The following is a description of a gene set: Human Gene Set: HP_ABNORMAL_PERIPHERAL_MYELINATION Abnormal peripheral myelination An abnormality of the myelination of motor and sensory peripheral nerves. These are axons for motor nerves and dendrites for sensory nerves in the strict anatomic sense. species: Homo sapiens, and this is the list of marker genes: ARSA, RAI1, MOCS1, WNK1, VRK1, PNPT1, ERCC6, MT-ND6, SLC12A6, TDP1, KCNJ10, JPH1, TWNK, SBF1, YARS1, CTDP1, DCAF8, SPTLC1, NEFL, POLG, PRX, MT-TV, TYMP, GCDH, PEX16, MME, COX6A1, RAB7A, MT-ND5, COQ7, ABCA1, PSAP, SURF1, MAT1A, MT-ND4, KLC2, FA2H, DHX16, LRPPRC, MT-TL1, MT-TW, ERCC8, MT-ND1, ELP1, KIF1A, FGD4, INF2, TFG (NCBI Gene Id 50989), SOX10, APTX, KIF1C, SACS (sacsin molecular chaperone), PLEKHG5, MT-ND3 (NCBI Gene Id 4537, mitochondrially encoded NADH:ubiquinone oxidoreductase core subunit 3), HYCC1, AFG3L2, NTRK1, PMP22, MTMR2, EGR2, HSPB8, FIG4 (NCBI Gene Id 9896), MORC2, FLRT1, SPG11, MPV17, TRIM2, MMACHC, GAN (NCBI Gene Id 8139), RRM2B, GBF1, NFU1, GDAP1, ASXL1, PMP2, MT-ATP6, GALC, SH3TC2, PLP1, VPS13A (vacuolar protein sorting 13 homolog A), MOCS2, NGF, ZNHIT3 (zinc finger HIT-type containing 3), RETREG1, PRPS1, MFN2, DNMT1, MT-ND2, SCN9A, LITAF, NDRG1, HACE1, SBF2, UBTF, LMNA, DNM2, MTTP, MTRFR, FLVCR1, GJB1, HK1, TYROBP, SPTBN1, KIF1B, SUMF1, ARHGEF10, ADCY6, MT-TK, GNB4, MPZ, LIG3, DHH